Given this list of marker genes RAD23B, COX7A2L, RAB6A, DAP3, PUM2, FAM120A, PPP2R5E, ZNF146, SMNDC1, TIAL1, SRP9, UTP18, LYPLA1, VGLL4, ATXN2, YWHAQ, MTDH, POGZ, UBR5, SNRNP200, IK, GPN1, EIF2B4, G3BP2, EBAG9, UBXN4, CALM2, SP3, RAC1, EIF4H, DRG1, CNBP, METAP1, MDH1, KHDRBS1 (KH RNA binding domain containing, signal transduction associated 1), MYL11, FBXW11, SET, ZZZ3, SUMO2, SYPL1, C6orf62, RBL2, HNRNPA2B1, PARG, RTN4, TRAPPC3, COPS5, COIL, SUMO1, PPP1R7, STARD7, G3BP1, PRKAR1A, URI1, GTF2H1, DEK, MARCHF7, BZW1, PSMC2, NONO, CANX, PSMB4, SPCS2, SERP1, BAG5, DNPEP, TMED2, ARCN1, PHF3, RAD21, PSMD7, YWHAB, RPA1, DYNC1I2, SEM1, ARPC5, GMFB, PRPSAP1 (phosphoribosyl pyrophosphate synthetase associated protein 1), here is a description of the gene set: species: Homo sapiens Neighborhood of SP3 Sp3 transcription factor in the MORF expression compendium Neighborhood of SP3 Human Gene Set: MORF_SP3